The following is a description of a gene set: Human Gene Set: GOCC_PHOSPHATIDYLINOSITOL_3_KINASE_COMPLEX A protein complex capable of phosphatidylinositol 3-kinase activity and containing subunits of any phosphatidylinositol 3-kinase (PI3K) enzyme. These complexes are divided in three classes (called I, II and III) that differ for their presence across taxonomic groups and for the type of their constituents. Catalytic subunits of phosphatidylinositol 3-kinase enzymes are present in all 3 classes; regulatory subunits of phosphatidylinositol 3-kinase enzymes are present in classes I and III; adaptor proteins have been observed in class II complexes and may be present in other classes too. studied in species Homo sapiens, and this is the list of marker genes: PIK3CB, PIK3R1, PIK3R5, PIK3CA, PIK3R6, PIK3C3, BECN2, ATG14, PIK3CG, PIK3CD, PIK3R3, UVRAG, PIK3R4 (NCBI Gene Id 30849), PIK3R2, NRBF2, BECN1